Given this list of marker genes NECTIN1, MT-CO1, AGRN, DOK7, MUSK, LPIN1, RAPSN, CACNA1S, OBSCN, AK9, GIPC1, ADGRG1, SRPX2, RYR1, LRP4, ATXN1, RILPL1, CHRNB1, CHRND, COL13A1, NOTCH2NLC, MSX1 (NCBI Gene Id 4487), SCN4A, PI4KA, FLNC, LRP12, CHRNE, TP63, CHRNA1, MT-CO3, IRF6, here is a description of the gene set: Human Gene Set: HP_ABNORMALITY_OF_JAW_MUSCLES species: Homo sapiens Abnormality of jaw muscles